Given this list of marker genes Hcn1, Gsdma2, Snap91, Sdcbp, Sestd1, Gsdmc2, Syt7, Plcz1, Osbpl2, Gbf1, Defb5, Tpcn1, Clvs1, Sh3pxd2a, Defb6, Pfn1, Adap2, Rag2, Gsdme (NCBI Gene Id 80642), Obscn, Jph2 (NCBI Gene Id 68450), Dnm1, Wdr45b, Chmp3, Kcnq1, Fzd7, Plek2, Amer1, Snx5, Washc2, Sh3pxd2b, Dnm2, Defb8, Scin, Tulp1, Gsdma3, Exoc7, Snx14, Dab2, Cfl1, Avil, Phlda3, Sdcbp2 (NCBI Gene Id 228765), Rs1, Snx21, Capg (capping actin protein, gelsolin like), Vil1, Hip1r, Rph3a, Frmpd4, Mtss2 (NCBI Gene Id 244654), Amer3, Anxa8, Mapkap1, Gsdmc4, Syt5, Defb7, Pard3, Kcnj3, Alox15, Acap2, Defb4, Fcho2, Laptm4b, Gsdmc3, Hip1, Snx20, Gsdmd, Syt3, Syt10, Twf2, Commd1, Svil (supervillin), Rlbp1, Syt1, Atp13a2, Snx3, Plekha5, Plcd1, Tirap, Pfn2, Anxa2, Ttpal, Ttpa, Myo1b, Gsdmc, Kcnj2, Tpcn2, Kcnj1, Plcb1, Apba1, Flii, Kcnh1, Rab35, Pirt, Myo1g, Mark1, Sytl2, Kif16b, Exoc1, Cadps, Pla2g4e, Twf1, Clvs2, Wipi2, Asap1, Krit1, Picalm, Defb3, Ldlrap1, Amer2, Gsn, Wipi1, Gramd2a, Cgas, Gsdma, Plekha4, Snx18, Actn2, Wdr45, Syt9, Vill, here is a description of the gene set: Binding to phosphatidylinositol bisphosphate. Mouse Gene Set: GOMF_PHOSPHATIDYLINOSITOL_BISPHOSPHATE_BINDING studied in species Mus musculus